The following is a description of a gene set: Mouse Gene Set: REACTOME_PROGRAMMED_CELL_DEATH Programmed Cell Death species: Mus musculus, and this is the list of marker genes: Ywhag, Opa1, Apip, Lmnb1, Dsg2, Dnm1l, Bid, Bcap31, Ywhaz (NCBI Gene Id 68643), Pkp1, Stk24, Bcl2l1, Mapk8, Satb1, Tjp1 (NCBI Gene Id 381892), Tnfsf10, Dffa, Casp1, Fadd, Ocln (NCBI Gene Id 18260), Prkcq, Ywhab, H1f2, Ripk1, Dynll1, Chmp6, Fasl, Chmp4c, Hsp90aa1, Mapk1, Dffb (NCBI Gene Id 13368), Il1b (interleukin 1 beta), Casp8, Fas, H1f1 (NCBI Gene Id 80838), Bad, Ctnnb1, Casp6, Appl1, Xiap, Apaf1, Sptan1, Ywhah, Dynll2, H1f5, Tnfrsf10b, Casp3, Chmp7, Casp7, Kpnb1 (karyopherin subunit beta 1, NCBI Gene Id 16211), Ubb, Hmgb1 (NCBI Gene Id 15289), Ripk3, Chmp4b, Ppp3cc, Chmp3, Il18, Stub1, Prkcd, Dsg1a, H1f0, Ywhaq, Cd14, Mapk3, Birc3, Casp9, Dsp, Pdcd6ip, Cdc37, Peli1, Gm10053, Gsn, Acin1, Tjp2, Tradd, Dcc, Elane, Chmp2b, Diablo, Bcl2, Aven, H1f4, Il1a, Plec, Gas2, Sfn, Oma1, Bak1 (NCBI Gene Id 12018), Bcl2l11, Tlr4, Apc, Vim, Gsdmd, Traf2, Ptk2, Rps27a, Cycs, Ube2l3, Fnta, Ticam1, Septin4, Uba52rt, Sdcbp, Uba52, Ywhae (tyrosine 3-monooxygenase/tryptophan 5-monooxygenase activation protein, epsilon polypeptide), Nmt1, Stk26, Ogt, Ppp3r1, Clspn, Casp4, Gsdme, Hmgb2, Mlkl, Bmx (BMX non-receptor tyrosine kinase), Sorbs2, Add1, Bmf, Flot2, Chmp2a, Prkn, Cflar, Rock1, Ubc, Birc2, Lmna, Bax, Kpna1, Itch, Dsg3, Mapt, Flot1 (NCBI Gene Id 14251), Pmaip1, Ly96, Gzmb, Ticam2